The following is a description of a gene set: Human Gene Set: GOBP_NEGATIVE_REGULATION_OF_MUSCLE_CELL_DIFFERENTIATION Any process that stops, prevents, or reduces the frequency, rate or extent of muscle cell differentiation. studied in species Homo sapiens, and this is the list of marker genes: TMEM119, RGS4, TOMM70, MIR199B, NFATC1, FRS2, CTDP1, PDCD4, MIR200B, CCN3 (cellular communication network factor 3), BMPR1A, RPL3L, MIR590, SOX6, DKK1, HEY1, FOXO4, NKX2-5, CEACAM5, PTBP1, NOTCH1, XBP1, SMAD4, YBX1, PDGFB, HDAC3 (NCBI Gene Id 8841), FGF9, NFATC2, PI16, EZH2, G6PD, MIR199A1, MED28, RGS2, FOXP1 (NCBI Gene Id 87246), IGF2, TCF23, NFATC3, ID2, MSX1, MIR222, MIR221, MIR21, YY1, ZBED6, CAV3, BHLHA15, PAK1, DNMT1, DLL1, HDAC5 (NCBI Gene Id 23342), GSK3A, HEY2, MIR15B, BMP2, TNPO2, BMPR2, TRIM72, SHH, HDAC1, PLPP7, HDAC4, MECP2, BHLHE41 (NCBI Gene Id 79365), FZD7, SMAD1, EREG, RCAN1, MIR100, MIR26A1, RBPMS2, PPARA, MYOCD, PRDM6, BDNF